Given this list of marker genes Chd8, Grin2a, Drd4, Grin3a, Drd2, Dvl1, Slc6a3, Drd3, Aph1c (NCBI Gene Id 68318), Nrxn1, Mdga1, Npas1, Prkn, Kcna1, Aph1b, Kcnh1, Grin2d, Mecp2, Get1, Ucn, Grin1, Pcdh15, Grid2, Otof, Penk, Drd1, Nlgn3, Adora2a, Bace1, Npr2, Dbn1, Slitrk6, Fabp7, Npas3, Grin2b, Glra1 (glycine receptor, alpha 1 subunit), Comt, Glrb, Csmd1, Ctnna2, Tuba1a, Pten, Grin2c, here is a description of the gene set: An action or movement due to the application of a sudden unexpected stimulus. Mouse Gene Set: GOBP_STARTLE_RESPONSE studied in species Mus musculus